The following is a description of a gene set: Extrinsic Pathway of Fibrin Clot Formation species: Mus musculus Mouse Gene Set: REACTOME_EXTRINSIC_PATHWAY_OF_FIBRIN_CLOT_FORMATION, and this is the list of marker genes: F9, F3, F10, Tfpi, F7